Given this list of marker genes Nat3, Ggt6, Ggt1, Abcc4, Gstm6, Ggt5, Ugt1a6a, Ugt2b36, Ugt1a7c, Abcc2, Ugt1a1, Abcg2, Ggt7, Gstt1, Abcc3, Ugt1a8 (UDP glucuronosyltransferase 1 family, polypeptide A8), Ugt1a9, Gstp1, Cyp2e1, Nat2, Nat1, here is a description of the gene set: Reactome Pathway: Paracetamol ADME species: Mus musculus electronically inferred by orthology from the curated human pathway part of: Drug ADME This event has been computationally inferred from an event that has been demonstrated in another species.<p>The inference is based on the homology mapping from PANTHER. Briefly, reactions for which all involved PhysicalEntities (in input, output and catalyst) have a mapped orthologue/paralogue (for complexes at least 75% of components must have a mapping) are inferred to the other species.